Given this list of marker genes Vcp, Mindy1, Ubxn1, Ubqln4, Ufd1, Ikbke, Mindy2, Rnf31, Zfand2b, Nploc4 (NCBI Gene Id 276977), here is a description of the gene set: Mouse Gene Set: GOMF_K48_LINKED_POLYUBIQUITIN_MODIFICATION_DEPENDENT_PROTEIN_BINDING Binding to a protein upon poly-ubiquitination formed by linkages between lysine residues at position 48 in the target protein. studied in species Mus musculus